Given this list of marker genes GSTA2, GSTT2, GSTK1, HPGDS, MGST1, GSTT1, GSTM2, GGCT, GSTZ1, GSTA4, GSTT2B, MGST3, GSTO1, GSTA3, AKR1A1, GSTM3, CNDP2, GGT6, OPLAH, GGT7, GCLM, GSTM5, GSTM1, GSS, ESD, GGT1, CHAC1, GSTA1 (glutathione S-transferase alpha 1), GGT5, GSTO2, CHAC2, GSTM4, GSTA5, GCLC, GSTP1, MGST2, here is a description of the gene set: Glutathione conjugation Human Gene Set: REACTOME_GLUTATHIONE_CONJUGATION species: Homo sapiens